Given this list of marker genes SCN2B (sodium voltage-gated channel beta subunit 2), CLCNKB, PRKAG2, MT-CYB, KCNA5, DSG2, TLL1, GABRA3, SLC12A3, GNB5, TRPM4, KCNJ18, GNB2, GPD1L, CACNA1S, MTFMT, NKX2-5, GAA, DOHH, SCN5A, here is a description of the gene set: Abnormal PR interval An anomaly of the PR interval, which is the portion of the ECG from the onset of the P wave to the beginning of the QRS complex. A normal PR interval in adults is 0.12-0.2 seconds. species: Homo sapiens Human Gene Set: HP_ABNORMAL_PR_INTERVAL